Given this list of marker genes Larp4, Avl9, Brk1, Hspa13, Ace2, Mospd2, Lman1, Ccdc148, Vmn2r81, Elavl4, Ipo5, Zmat3, Fgfr1, Ap4e1, Hapstr1, Rnf138, Dcun1d1, Nfib, Hecw2, Zbtb44 (zinc finger and BTB domain containing 44), Synj2bp, Rc3h2, Fnip1, Slc6a1, Snap91, Mindy3, Col19a1, Lcorl, Pth2r, Mlec, Rundc1 (RUN domain containing 1), Yipf5, Runx1t1, Slitrk1, Rps6ka6, Septin8, Commd3, Onecut2, Acvr1, Ldb2, Nudt4, Slf1, Vav1, Kbtbd8 (kelch repeat and BTB (POZ) domain containing 8), Taok1, B4galt5, Tbc1d15, Spred1, Naa50, Slk, Crebrf, Nfyb (NCBI Gene Id 18045), Atp11c, Fam177a2, Anxa3, Spryd7, Retreg1, S2bpcox16, Rprd1a, Zfp292, Asb1, Ttc14, Ift43, Bcat1 (branched chain aminotransferase 1, cytosolic), Pten, Mpzl2, Ash1l, Slc1a4, Sanbr, Strap, Chl1, Cnep1r1, Ptpn21, Tent5d, Hook3, Cpeb2, Slc35e3, Pias1, Rbm26, Bclaf3, Msantd4, Cap2, Fam169a (family with sequence similarity 169, member A), Ccpg1, Frrs1l, Arid1a, Rimklb, Glcci1, Vegfa, Zfp672, Shprh, Snx18, Dennd5b (DENN domain containing 5B), Hnrnph3, Jund, Fam186b, Lrch2, Tox3, Trim66, Mbd4, Tgfbr3, Cd164, Dach2, Hells, Pkd2l2, Ryr3 (NCBI Gene Id 99099), Qser1, Asxl3, Msn, Cherp (calcium homeostasis endoplasmic reticulum protein), Evi5, Hivep1, Cetn4, Zic5, Nova1, Nabp1, Csrnp3, Homer1, Fam228b, Adprh (NCBI Gene Id 11544), Gabarapl2, Rdx, Csnk1g3, Fam149a, Arhgap42, Egr1, Peli2, Mblac2, Mecp2, Adipor2, Ncam2, Atrx, Gramd1c, Map3k7, Ski, Pds5b, Fzd3, Elavl2, Lancl3, Aff3, Rbm47, Wnk3, Gask1a (golgi associated kinase 1A), Clec1a, Vcf2, Zbtb10, Prkar1a, Gpc2, Hsf3, Il13ra1, Irs4, Ddx3x, Pcbp2, Rbbp6, Sar1a, Polr3e, Pex13, Mbnl1, Radx, Fbxo6, Usf3, Dcx, Trim44, Cert1, Gnb2, Heph, Zfp329, Mgat2 (NCBI Gene Id 217665), Sestd1, Thrb, Srsf3, Kif5b, Edar, Myef2, Pknox2, Adamts5, Trpc5, Smad1, Oat, Rbm14, Adamtsl3, Eny2, Hprt1, Npat, Erbin, Gnpda1, Srsf12, Rbm4b, Ift70b, B4galt6, Fndc3b (fibronectin type III domain containing 3B), Usp32, Plekha1, Dcp2, Casp12, Smco3, Nell2, Thsd1, Dnajb6, Il15ra, Arhgap6, Clasp1, Nab1, Pglyrp2 (NCBI Gene Id 623596), Hspa12a, Atl2, Bloc1s6, Rasa1, Eif2s3y, Rspo2, Ppig (NCBI Gene Id 228005), Fam177a, Mgat4c, Polr1b, Phactr3, Mss51, Dppa1, Mex3c, Lrrk2, Dnaaf9, Atg4b, Kmt2d, Usp3, Cox16, Tafa5, Pnn (pinin), Hipk1, Rp1, Eloc, Stxbp5, Ppp1r21 (NCBI Gene Id 73825), Ikzf4, Trhde, Rtf1, 2310002L09Rik, Gnas, Smg1, Ammecr1, Bmpr1a, Thoc2, Adam1b, Azi2, Cadm2, Nr3c1, Or4d10c, Lonrf2, Elf2, Bmt2, Tmod3, Khdrbs1, Cnksr2, Usp42, Sgcd, Nfat5 (nuclear factor of activated T cells 5), Clk1, Prkch, Dtna, Igsf9b, Pcbp1, Prg4, Lpcat2, Zfp39, Myt1, Tcf12, Rnf13, Pik3cb, Arl8b, Dlg1, Osbp, Nr3c2, Tacc1, Slc8a1, Lrp8, Egfl8, Plag1, Spag9, Ube4b, Orc2, Crebzf, Cfl2, Zfp760, Ate1, Gm3383, Zcchc2, Tmem59, here is a description of the gene set: Genes predicted to be targets of miRBase v22 microRNA mmu_miR_6481 in miRDB v6.0 with MirTarget v4 prediction scores > 80 (high confidence targets). from publication Chen Y, Wang X (PMID 31504780) studied in species Mus musculus Mouse Gene Set: MIR_6481